The following is a description of a gene set: Human Gene Set: MYCMAX_02 species: Homo sapiens Genes having at least one occurrence of the motif NANCACGTGNNW in the regions spanning 4 kb centered on their transcription starting sites. This matches the MYC, MAX transcription factor binding site V$MYCMAX_02 (v7.4 TRANSFAC)., and this is the list of marker genes: C1QTNF5 (NCBI Gene Id 26141), CNNM1, NUP62CL, DSCAM, PMEL, NR1D1, CDKL5, TNFRSF21, ADSS2, TOP3A, UVRAG, SMAD2, SLC12A4, PSME3, EPB41L3, BCL9L, LZTS2, TMEM109, PLAG1, CLCN2, NOTCH1, LRP5 (NCBI Gene Id 8058), RNF128, PPP1R9B, RCOR2 (NCBI Gene Id 283248), OGN, HNRNPDL, ENPP2, PRDM4, RLIM, TXNDC12, LEF1 (NCBI Gene Id 51176), FGF20, SGCD, TMEM156, KCNQ5, VGF, CALB2, RSPO2, URI1, HOXC11, GPS1, ADD3, SYT6, MAN2A2, APLN (NCBI Gene Id 8862), TSC22D2, ZC3H10, BHLHA15, OPRD1, RAI14, EPB41L4B, POGK, ANKHD1-EIF4EBP3, KANSL3, MIDEAS, H3-3B, USP15, RBM26, TIMM8A, MBNL1, IPO13, TYRP1, DCAF17, BACH1, LRRC2, HSPH1, LEMD2, SOX12, FGF6, SLC1A7, NR5A1, HOXA11, DBP, LINC01106, FAM89B, NAA50, ATOH8, NPHS1, LSM14A, IQGAP2, ATF7IP, CDK5R1, COL2A1, UTP4, GLS2 (glutaminase 2), MAP7, EN1, CDK2, FOXF2, TGIF2, DIABLO, EXOSC5, PTMA, B3GALT2, TOGARAM1, INO80, RAB35, RSPRY1, KLHL28, E2F8, DCAF13, ARRDC3, OBI1, TMEM59L, MAX, DLX1, NTN3, BACH2, RPS2, POLR2H, UBR4, POLR3E, TYR, TXLNG, PRKCH, BCOR, GPR17, TGFB2, FGF14, CDKN2C, PPP2R2B, HOXD10, DCT, UBE2B, BMP2K, UBXN10 (UBX domain protein 10), GSX1, GATA4, PHF20, DNAAF6, NACA, KDM3A, CAD, TYRO3, TMEM132E, IP6K1, GRHL3 (grainyhead like transcription factor 3), VNN1, NOLC1, METTL8, EFNB1, IRF9, ANGPT2, FKBP5, ADAMTS17, DZIP1, EPB41, TMEM132E-DT, SMCR8, KCNT2, SERBP1, RTN4RL2, OSR1, KMT2A (NCBI Gene Id 79951), CBX5, TENM1, HSPA4, WDR17, CSK (NCBI Gene Id 1445), NEUROD6, LIN28A, GALNT4, HDGF, RUNX2, CIART, IGF2BP1, HNRNPA1, SYBU, RAB30, PCDHA10, ZFP91, XPO1, CARMIL3, FGF19, USP36, CHST11, BEND4, WRAP53, MKRN3, GPC3, ARHGAP44, PA2G4, PTCHD4 (patched domain containing 4), TIMM10, INSM1 (NCBI Gene Id 8196), HOXA7, CSMD3, CCDC6, PRKCG, JMJD1C, DPAGT1, ANKRD17, CUTA, SEMA7A, BCKDHA, KBTBD2, MTHFD1, ACY1, MAML3, FZD6, RASGEF1B, KICS2, IGF1R (insulin like growth factor 1 receptor), NEUROD2, CITED1, IER5L, PSME3IP1, TOP1, FRMD4A, PTCH1, NMNAT2, PABPC4, SYNCRIP, TCF4, HOXC4, COMMD3, UMPS, MORF4L2, EIF4B, ETV1, AMPD2, DCAF11, TFAP4, FBL, HOXA3, IRS4, FXR1, ZNF296, HOXB5, LPXN, IVNS1ABP, HIF1A, PPRC1, H2AZ1, TIMP3, PTK7, GPR65, JADE1, SATB2, ARF6, PRR7, ATXN7L2, SEPTIN3, SOX10, MAT2A, STAT3, L1CAM, OSM, FBXW7, GIT1, LMO3, POC1B, RCL1, CD2, MAEL (maelstrom spermatogenic transposon silencer), WFIKKN2, PPM1A, NPM1, HOXB7, TESK2, ANKHD1, CLUH, SCRT2, TP53, PRMT1, USP34, MICU1, HPCA, CACUL1, CAMKV, BOK